The following is a description of a gene set: species: Homo sapiens Reactome Pathway: Respiratory syncytial virus (RSV) attachment and entry part of: Respiratory Syncytial Virus Infection Pathway The entry of human respiratory syncytial virus (RSV) into host cells involves attachment of the virion to the host cell surface, through interaction of viral envelope proteins with host cell attachment factors, and fusion of the viral membrane with the host cell membrane. The G glycoprotein is the attachment protein that interacts with surface molecules of the host cells, enabling the RSV virions to bind to their target cells. While the F glycoprotein may facilitate attachment, its primary function is to promote fusion of the viral and host cell membranes. The SH protein is dispensable for entry. For review, please refer to Battles and McLellan 2019.<br><br>Using human primary airway epithelial cell cultures, it was established that RSV efficiently infects the airway epithelium from the luminal surface and specifically targets ciliated airway epithelial cells. In the absence of immune response, RSV causes no obvious cytopathology.<br><br>In addition to ciliated respiratory epithelial cells, RSV may infect granulocytes and cause a delay in constitutive apoptosis of neutrophils and eosinophils. RSV can also infect neonatal-specific regulatory B cells, which may contribute to high viral load and disease severity in infants., and this is the list of marker genes: RAB5B, GPC6, Human respiratory syncytial virus A2, complete genome, FURIN, IGF1R, HSPG2, G, RAB5A, RAB5C, CD14, SDC1, SDC3, CX3CR1 (NCBI Gene Id 2836), GPC2, SDC4, M2-1, LY96, GPC3, GPC1, GPC5, SDC2, N, P, M, GPC4, L, NCL, SH, AGRN, TLR4, EGFR, F